The following is a description of a gene set: Reactome Pathway: Platelet activation, signaling and aggregation Platelet activation begins with the initial binding of adhesive ligands and of the excitatory platelet agonists (released or generated at the sites of vascular trauma) to cognate receptors on the platelet membrane. Intracellular signaling reactions then enhance the adhesive and procoagulant properties of tethered platelets or of platelets circulating in the proximity. Once platelets have adhered they degranulate, releasing stored secondary agents such as ADP, ATP, and synthesize thromboxane A2. These amplify the response, activating and recruiting further platelets to the area and promoting platelet aggregation. These amplify the response, activating and recruiting further platelets to the area and promoting platelet aggregation. Adenosine nucleotides signal through P2 purinergic receptors on the platelet membrane. ADP activates P2Y1 and P2Y12, which signal via both the alpha and gamma:beta components of the heterotrimeric G-protein, while ATP activates the ionotropic P2X1 receptor. Activation of these receptors initiates a complex signaling cascade that ultimately results in platelet activation, aggregation and thrombus formation. Integrin AlphaIIbBeta3 is the most abundant platelet receptor, with 40 000 to 80 000 copies per resting platelet, acting as a major receptor for fibrinogen and other adhesive molecules. Activation of AlphaIIbBeta3 enhances adhesion and leads to platelet-platelet interactions, and thus aggregation. GP VI is the most potent collagen receptor initiating signal generation, an ability derived from its interaction with the FcRI gamma chain. This results in the phosphorylation of the gamma-chain by non-receptor tyrosine kinases of the Src family (1). The phosphotyrosine motif is recognized by the SH2 domains of Syk, a tyrosine kinase. This association activates the Syk enzyme, leading to activation (by tyrosine phosphorylation) of PLC gamma2 (2). Thrombin is an important platelet agonist generated on the membrane of stimulated platelets. Thrombin acts via cell surface Protease Activated Receptors (PARs). PARs are G-protein coupled receptors activated by a proteolytic cleavage in an extracellular loop (3). Activated PARs signal via G alpha q (4) and via the beta:gamma component of the G-protein (5). Both stimulate PLC giving rise to PIP2 hydrolysis and consequent activation of PI3K (6). PLCgamma2 activation also gives rise to IP3 (7) which stimulates the IP3 receptor (8) leading to increased intracellular calcium. Platelet activation further results in the scramblase-mediated transport of negatively-charged phospholipids to the platelet surface. These phospholipids provide a catalytic surface (with the charge provided by phosphatidylserine and phosphatidylethanolamine) for the tenase complex (formed by the activated forms of the blood coagulation factors factor VIII and factor I). part of: Hemostasis species: Homo sapiens, and this is the list of marker genes: CFL1, DGKZ, PDPK1, CDC37L1, GNG8, HABP4, SELP, RAC1, GNB1, VCL, PRKCG, FGA, TEX264, GNA14, RASGRP1, GNG11, TIMP1 (NCBI Gene Id 7076), RAP1A, LEFTY2, FN1, FYN, RARRES2, GNAI3, SOD1, CSK, F2R, GTPBP2, BRPF3, SERPING1, CDC42, SERPINA1, SYK, DAGLA, F8, PRKCA, EGF, FERMT3, GNA11, ORM1, ADRA2B, GNAT3, MGLL, GNG5, TMSB4X, SERPINA4, GNB3, DGKK, IGF2 (insulin like growth factor 2), DGKD, GNAQ, CHID1, RHOG, PDGFA, RAB27B, PRKCZ, TMX3, PDPN, LGALS3BP, MMRN1, MANF, SERPINA3 (NCBI Gene Id 95022), ALB, CAP1, PPBP, LHFPL2, TOR4A, SHC1, FGG, RHOB, SERPINE1, PRKCH, VAV2, ALDOA, HSPA5, ENDOD1, PIK3CB, PDGFB, ECM1 (NCBI Gene Id 1893), TLN1, SPP2, GNGT2, ADRA2A, AAMP, VEGFB, THBS1, LY6G6F, DGKB, F13A1, ARRB2, RAF1, GRB2, SCCPDH, VWF, ITPR2, SCG3, FCER1G, PRKCQ, GP9, MAPK14, STXBP2, GNG3, ITIH4, TGFB1, DGKE, GP1BB, PRKCD, LAMP2, GP5, LAT, RASGRP2, ANXA5, ITGB3, MAPK3 (mitogen-activated protein kinase 3), ITPR3, CALM1, GNG13, AHSG, GAS6, A1BG, CD109, PLG, VAV3, PTPN11, DGKG, CYB5R1, GNA15, RHOA, P2RY12, TRPC7, RAP1B, TGFB3, PHACTR2, FLNA, GNB2, PTPN6, A2M, SRGN, COL1A2, MAPK1, ACTN2, PIK3R2, THPO (NCBI Gene Id 84434), GNB5, KNG1, DGKI, F5, DGKA (diacylglycerol kinase alpha), GNA12, SERPINF2, TUBA4A, ITIH3, WDR1, PPIA, BCAR1, HRG, FGB, TGFB2, ADRA2C, ACTN1, GNAI2, TBXA2R, DGKH, PF4, CLU, ORM2, VEGFD, POTEKP, CD36, F2RL2, MPL, CFD, YWHAZ, PCDH7, SELENOP, APOOL, PLCG2, GNG12 (G protein subunit gamma 12), DGKQ, APLP2, SPARC, APOA1, MPIG6B (NCBI Gene Id 80739), CYRIB, ITGA2B, ABHD6, PRKCE, PIK3R6, GNA13, TTN, F2, ARRB1, ISLR (NCBI Gene Id 3671), SYTL4, GNB4, LYN, GNG4, GNG7, CD63, RAC2, PTPN1 (NCBI Gene Id 5770), MAGED2, ACTN4, IGF1, GNGT1, VAV1, PIK3R1, GNAI1, HGF, GNG10 (NCBI Gene Id 2790), P2RY1, GP6 (NCBI Gene Id 51206), APOH, PECAM1, CLEC3B, PLA2G4A (NCBI Gene Id 5321), TIMP3, GNG2, TRPC6, CRK, COL1A1, FAM3C, AKT1, PSAP, PRKCB, ABHD12, PIK3R5, DAGLB, APP, TRPC3, ITPR1, CTSW, PROS1, NHLRC2, TAGLN2, RAPGEF3, SRC, STXBP3 (NCBI Gene Id 730947), ABCC4, OLA1, PIK3R3, GP1BA, QSOX1, CLEC1B, CD9, TF, VTI1B, CALU, RAPGEF4, PIK3CG, VEGFC, STX4, PLEK, LCP2, PTK2, VEGFA, PIK3CA, LCK, F2RL3, SOS1, APBB1IP, PFN1, PCYOX1L